The following is a description of a gene set: To identify the molecular mechanisms by which EBV-associated epithelial cancers are maintained, we measured the expression of essentially all human genes and all latent EBV genes in a collection of 31 laser-captured, microdissected nasopharyngeal carcinoma (NPC) tissue samples and 10 normal nasopharyngeal tissues. Global gene expression profiles clearly distinguished tumors from normal healthy epithelium. Expression levels of six viral genes (EBNA1, EBNA2, EBNA3A, EBNA3B, LMP1, and LMP2A) were correlated among themselves and strongly inversely correlated with the expression of a large subset of host genes. Among the human genes whose inhibition was most strongly correlated with increased EBV gene expression were multiple MHC class I HLA genes involved in regulating immune response via antigen presentation. The association between EBV gene expression and inhibition of MHC class I HLA expression implies that antigen display is either directly inhibited by EBV, facilitating immune evasion by tumor cells, and/or that tumor cells with inhibited presentation are selected for their ability to sustain higher levels of EBV to take maximum advantage of EBV oncogene-mediated tumor-promoting actions. Our data clearly reflect such tumor promotion, showing that deregulation of key proteins involved in apoptosis (BCL2-related protein A1 and Fas apoptotic inhibitory molecule), cell cycle checkpoints (AKIP, SCYL1, and NIN), and metastasis (matrix metalloproteinase 1) is closely correlated with the levels of EBV gene expression in NPC. Human Gene Set: SENGUPTA_NASOPHARYNGEAL_CARCINOMA_WITH_LMP1_UP species: Homo sapiens Genes up-regulated in nasopharyngeal carcinoma (NPC) positive for LMP1, a latent gene of Epstein-Barr virus (EBV). from publication Sengupta S, den Boon JA, Chen IH, Newton MA, Dahl DB, Chen M, Cheng YJ, Westra WH, Chen CJ, Hildesheim A, Sugden B, Ahlquist P (PMID 16912175), and this is the list of marker genes: CHRNA7, TTC14, PRKAR2B, ELSPBP1, PTGS2, HNMT, CLDN18, BLVRA, USP16, NASP, SNHG4, DYRK2, DDX17, MACIR, LARP6, LSM5, SAP30, NEDD1, PHACTR3, HYCC2, CP, PDP1, NEXN, FAM171B, ZNF804A, IGF2BP3, HEPACAM2, MMP1, DESI2, RNASE4, TRIM5, NT5DC1, SCAMP1, XKR4, VPS35, LYAR, GALNT7, DCUN1D1, LPL, ADGRL2, SF3B1, PHLDA2, KLHL13, FAM120A, NR1D2, SMC3, USP37, ILF3, PTAR1, ABCA17P, TFPI, DNAJC3, MEOX2 (NCBI Gene Id 4223), FAR2, MIR99AHG, ZFY, POSTN, NORAD, POPDC3, MDM2, ESF1, EPRS1, LIN28B, ADA (NCBI Gene Id 100), IFIT3, TTC3, SULF1, SMCHD1, PLAG1, SGO2, MALAT1, KRBOX1, LGALS4, SPIN1, UBXN4 (UBX domain protein 4), SERPINI1, SYNC, ENPP2, ENSG00000251616, GNG12, KYNU, SYNCRIP, CMPK2, ATRX, USP1, CAPZA2, CLIC2, FOXA1, RIMS2, PTPRR, ZNF22, APPL1, MCTP1, THAP6, TFG, CDC25A, CEL, WDR72, HLA-DQA1, RBBP4, CAPN8, CYP4X1, SIM1, PLAT, CATSPERB, AVIL, PPM1K, MOCOS, CEP76, NBPF14, TNFRSF11B, LRP12, NADK2, C4orf46, ADCY10, NAA15, MMP10, ZNF678, ENSG00000293607, SREK1, ZMAT3, CEP290, WDR3, MCTP2, TOP1, SART3, SPIC, UBE2W (ubiquitin conjugating enzyme E2 W), IGLV9-49, HSPA4L (heat shock protein family A (Hsp70) member 4 like), PKIB, ASPM, USO1, CHD4, ESRG, LYPLA1 (NCBI Gene Id 105375839), TC2N, CYP7B1, CNR1, DMD (dystrophin), GJB6, ZBTB10, RIF1, OAS1, SOX8, FOXP2, NKTR, ASB17, PKP4, FAM98A, BCLAF1, CSAG3, SNCAIP, LMO7, TXLNGY, SLCO1A2, OTX2, SETD9, INSYN2B, PAPPA, LTN1, CDC42BPA, PGM5, CTTNBP2, TGS1, SLC7A11, LPAR3, WDFY1, NRXN1, CLK4, PRTFDC1, HSPD1, CSPP1, GHR, ADAMTS5, PPIA, TRIM2, MIB1, MBNL2, ADGRG2, SMC5 (NCBI Gene Id 23137), CROT, MEGF10, SAMD9L, SUCNR1, DHRS2, SFXN1, NCEH1 (NCBI Gene Id 57552), TBL1XR1, RSAD2, LUC7L3, ZMYM2, SON, RASSF6, HMGA2, HEPH, EIF3F, CXCL8, GDF15, ANKRD36B, SLC30A4-AS1, FLRT2, OXR1, REL, MATN2, UGT8, TNFRSF11A, ELL2, PRRX1, LPGAT1, FMNL2, TWSG1, ALCAM, HERC5, NPAS3, DNM3, CDKAL1 (CDK5 regulatory subunit associated protein 1 like 1), KLF5, CADPS, HSPA4, IRAK3, SEC63, IGSF10, COX10-DT, G2E3, ZNF567, TNC, IFIT1, ST13, FAM98B, PKN2, WASL, SFRP2, SLC25A32, B3GALNT1, TRIM36, PPIG, GALNT1, FBXW7, TRNT1, DYNC1I1, PSME4, GREM1, RBM39, IFIT2, CEP57, EIF1AY, SINHCAF, FXYD2, CEP295, SPINK1, HELLS, PDE5A, C5orf24, C3orf52, NDUFS1, RBM25, TFEC, MTHFD2, HAND2-AS1, SLCO4C1, PTHLH, RBM26, FST, MTAP, IL15, CPEB4, LINC00964, FNDC3B, CHROMR, C14orf39, PDC, HAUS6, RPE, KLHL24, BCL2, TRPA1, SSBP2, SLC44A5, HBS1L (HBS1 like translational GTPase, NCBI Gene Id 22991), BMP2K, RAP2A, PTX3, SLC22A3, THRAP3, IPO7, ZC3H11A, HSP90AA1, ESCO2, EIF5A2, PTPRG-AS1, IQGAP1, SHISA2, MAP3K20, BOD1L1, B4GALT6, TOP2A, SDHAF3, CHRM3, TMEM158, LIMS1, VWDE, TCF4, SEH1L, WASHC4, IMPACT, SLC25A36, GXYLT1, TFAM, ANO1, DSC3, USP18, LINC01806, TMTC1, SPAG9, NEAT1, ING3, SLC25A33, PMAIP1, MPPED2, EPHA4, LIFR, PSG5, UGT2A3, RBMS3, DHX9, RPRD1A, LACTB2, NETO2, TPR, HSP90B1, C2CD4A, ADAMTS1, ASB9, BCL2A1, XAF1, DSC2, MUC15, CFTR, AK3, FYB2 (NCBI Gene Id 199920), SERBP1, SYBU, VASH2, LINC02986, ENSG00000294531, ARHGAP18, ZNF277, DNAJC21, ANKRD20A1, KRAS, HSP90AB1, FABP4, KIT, TGFB2, ANXA3, EHF (ETS homologous factor), ESRRG, ZPLD1, RET, TALAM1, SCGB2A1, MBNL1, NAMPT, CYCS, PRMT3, KL, MYO6, QSER1, PPA2, DNAJB14, SLC12A2, RGS1, POLR3G, MOB1A, SQLE, CCDC50, SLITRK6, GATM, PIR, TNFRSF19, HOXA9, CCL15, CLSTN2, PRKD3, SESN3 (NCBI Gene Id 143686), DDHD1 (DDHD domain containing 1), MIR374C, PAPOLA, CFH (complement factor H), FAIM, MEST, F5, OLA1, CBX3, CD274, ODAM, ENPP4, FABP7, SPIB, EIF4G1, FAR1, CRYZ, CRISP3, PARM1, CALB1 (calbindin 1), DDX3Y, IGFBP5